Given this list of marker genes Ins2, Ins1, Rps19, Dusp10, Slamf8, Grn, here is a description of the gene set: species: Mus musculus Any process that decreases the rate, frequency or extent of a phase of elevated metabolic activity, during which oxygen consumption increases made as a defense response; this leads to the production, by an NADH dependent system, of hydrogen peroxide (H2O2), superoxide anions and hydroxyl radicals. Mouse Gene Set: GOBP_NEGATIVE_REGULATION_OF_RESPIRATORY_BURST_INVOLVED_IN_INFLAMMATORY_RESPONSE